Given this list of marker genes Stk32a, Nlgn2, Gpr26, Marveld3, Spo11, Vamp5, Fads3, Trpm6, Mettl24, Kcnip1, Phf1, Phox2a, Loxl4, Tsnax, Acp7, Tnfrsf25, Emilin3, Cdo1, Cimap1b, Gpx7, Abcc8, Rhcg, Dkk3, Lypd6b, Ccn2, Lhx3, Adora2a, Tbr1, Alox12, Hs3st2, Abtb3, Omp, Ddit4l, Taf7l, Grin2c, Znrf4, Glt28d2, Cdkl1, B3gnt8, Tacstd2, Tpm2, Rasd1, Gipc2, Grin3b, Anxa11, Large2 (NCBI Gene Id 99127), Cmtm7, Nrxn2, Pctp, Pcsk9, Nlrx1, Phactr3, Mex3a, Abcb1a, Eppk1, Syt16, Them7, Adss1, Hhat, Matn4, Efnb3, Slc39a8, Hebp1, Slc16a11, Npepl1, Npas4, Prrt3, Tubb4a, Pde4dip, Rnf17, Lekr1, Scin (scinderin), Chst5, Clvs2, Ptgis, Cspg4, Moxd1, Ctsz, Gfra3 (NCBI Gene Id 98132), Nox4, Aqp3, Terb1, Prdm14, Actl7b, Plscr4, Zfp641, Tmco4, Rpp25, Wnt3, Igfbp6, Parp14, Niban1, Cpne7, Scnn1b, 4930524B15Rik, Itgb4, Kcnh7, Selenov, Klhl14, Itpripl2, Dpp6, Fgf16, Gm5878, Naa11, Rarb, Cblc, Shroom1, Ppl, Prkar1b, Ssh3, Sowahd, Ripor2, Dusp9, Lin7b, Artn, Htra3, Mansc1, Krt19, Camkv, Dnajb3, Gsn, Tdh, Slc6a2, Rasgrf2, Gpr156, Prr15, Ezhip, 1700003F12Rik, Vsx2, Adamtsl5, Bmp8b, Bcat1 (branched chain aminotransferase 1, cytosolic), Irs3, Gpr176, Crispld2, Gldn, Sycp2 (NCBI Gene Id 83600), Dazl, Tfap2e, Ccn3, Gypc, Gpx3, Ifitm10, Galnt6, Mmp14, Slc44a3, Col26a1, Trim58, St14, Tmem30b (transmembrane protein 30B), Stat5a, Asic2, Mpv17l, 2810021J22Rik, Pcdhga11, Fgf22, Npy5r (neuropeptide Y receptor Y5), Cldn7, Pdgfd, Slc22a4, Gjb6, Trim25, Cd83 (CD83 antigen), Rassf10, Lpcat2, Oxtr, Sycp3, Il12rb2, Kcp, Cldn11, Gucy2e, Barhl1, Itga4, Grhl2, Clic6, Abcb9, Thbd, Cerkl, Ngb (NCBI Gene Id 64242), Rax, Cldn3 (claudin 3, NCBI Gene Id 12739), P2rx5, Adcy7, Pkp1, Cavin3, Ap1g2, Plekhg6, Mocos, Myocd, Slco2a1, Ccdc106, Sstr1, Ppp1r3b, Stac, Acot6, Sp5, Ap1s3, Cracr2b, Minar1, Rab42, Oxt, Mfsd6l (major facilitator superfamily domain containing 6-like), Fads6, C130074G19Rik, Ankrd53, Ngf, Larp6, S1pr3, Fah, Cxcl16, Fam83g, Ttc22 (tetratricopeptide repeat domain 22), Ntsr2, Ano5, Dhtkd1, Slc26a8, Ndrg2, Gna14, Gfra2, Tmem37, Shd, 1700001O22Rik, Bfsp1, Ky, Cpne9, Dhh, Rin3, Gabrq, Dusp26, Cyp2r1, Slc18a2, Lamc3, Wt1, Fut4, Slit1, Slc47a2, Mael, Gcnt1, Fbrsl1, Caln1, Mab21l1, Far2, Echdc2, Grin2a, Abcg4, Gal, Sptbn4, Pllp, Pkdrej, Fgfr4, Birc3, Nap1l5, D1Pas1, Gng13, Hormad1, Ccdc158, Gsdmd, Sowaha, Il27ra, Rasl10a, Cd302 (NCBI Gene Id 98862), Ece2, Rarg, Tmem171, Insrr, Lrrc15, Kremen2, Htr1f, Grb10, Mcub, Amn, Afap1l1, Eps8l2 (EPS8-like 2), Ush1g, Mapk13, Pitpnm1 (phosphatidylinositol transfer protein, membrane-associated 1), Cdcp1, Olig3, Fbln7, Trim36, Taf9b, Arhgap27, Cwh43, Rasef, Plbd1, Plcd1, Prrg3, Des, Pdlim2, Krt87, Glp1r, L3mbtl4 (L3MBTL4 histone methyl-lysine binding protein), Gmip, Slc47a1, Esyt3, Prom2, Cdx1, Castor1, Rem1, Slc9a3, Mpig6b (NCBI Gene Id 106722), B3gnt3, Trim47, Eef1a2, Sgk3, Nags, Gpr83, Dmc1, Vsir, Tdrd1, Arhgef4, Olfm2, Slc16a3, Myod1, Cygb, Bhlha15, Esrp2, Dcdc2a, Nr4a3 (nuclear receptor subfamily 4, group A, member 3), Liat1, Shisal2b, Papolb, Aldh1b1, Cdk18, Tcf20, Lpl (NCBI Gene Id 16956), P2rx2, Cst6, Kcnk4, St6galnac2, Tubg2, Evc, Ttc38, Nodal, Basp1, Kcna6, Ctsh, Thsd7b, Lhx9, Naprt, Spmip6, Myo5c, Car4, Drd5, Scarf2, Msh4, Shtn1, Col8a2, Dbx2, Ltb4r2, Kdf1, Lamc2, Fam163a, Fabp3, Lgals3, Tmprss2, Bhlha9, Qrfprl, Wdr86 (NCBI Gene Id 68216), Krt18, Pramel1, Prss50, Tspan2, Slc45a1, Dsc2, Klk8, Fstl3, Galr1, Sstr4, Nipal4, Or2i1, Speg, Crppa (NCBI Gene Id 75847), Ccdc125, Rnf225, Cldn4, Tfcp2l1, Loxl1, Flywch2, Lgi3, Vstm4, Agbl2, Hsf4, Krt7, Rnh1, Ntf3, Fam110c (family with sequence similarity 110, member C), Cd164l2, Lbx2, Il17rb, Cldn5, Pheta2, Ppm1j, Slc5a5, Htra4, Slc7a10 (NCBI Gene Id 53896), Foxi2, Kcnj6, Ric3, Eva1b, Spag6l, Fgf17, Cyp4v3, Tnfaip2, Scx, Ddx4, Sybu, Dnaaf6, Prkag2, Henmt1, Irf6, Kcnk13, Sox7, 5730409E04Rik, Gnmt, Syce2, Spag16, Bspry, Adad1, Ripply3, Ncmap, Tmem59l, Kcng1 (NCBI Gene Id 99379), Chmp4c, Doc2b, Kl, Rbm43, Prorsd1, Tdrd6, Aard, Slc30a2, Sec31b, Adgrg2, Tacr3, Tmem54, Ano1, Scara3, Sh3d21, Prlhr, Wnt10b, Sdr39u1, Paqr5, Hif3a, Irak3, Htatip2, Camkk2, Ntsr1, Ildr1, Cul9 (cullin 9), Ncoa4, Hand1, Ass1, Ltbr, Smc1b, Slc25a31, Cyba, F11r, F2rl1, Atp2a3, Adgrv1, Nscme3l, Isyna1, Flot2, Ap1m2, Hsf5, Slc13a3, Slc1a1, Cavin1, Rmdn2, Tnfrsf10b, Npb, Cyp24a1, Themis2, Kbtbd12, Hspa12a, Mmp23, Fkbp6, Ptger2, Cyp4f39, Gpr12, Sec1, Zfp709, Mgarp, Rbmxl2, Dsg2, Entpd2, Rab3b, Gca, Tnxb, BC030500, Arsj, Pgm5, Mycs, Fbxo17, Slc2a12 (NCBI Gene Id 353169), Cacng2, Irx4, Emid1, Lhfpl5, Parvb, Dlgap1, Slc6a11 (solute carrier family 6 (neurotransmitter transporter, GABA), member 11), Spata32, Adgre5, Thbs4, Slc34a2, Mmp25, Sycp1, Rgcc, Htr2c, Bcl3, Dpep3 (NCBI Gene Id 71854), Mal2 (NCBI Gene Id 223579), Map10, Pkib, Nipal2, Tmc8, Fgf20, Gsap, Casp8, Mcoln2, Sema4f, Dmgdh, Dmrta1, Pcnx2, Psd2, Arsi, P4htm, Pdha2, Shroom3, Mtarc1, Slc25a21, Osmr, Ehbp1l1, Lingo3, Spag6, Rhbg, Corin, Marveld2, Mesp2, Heyl, Spmap2l, Pik3r5, Afap1l2, Mmp2, Chrna3, Eogt, Drgx, Chchd10, Edn3, Kcnk9, Shfl, here is a description of the gene set: Genes with high-CpG-density promoters (HCP) that have no histone H3 methylation marks in neural precursor cells (NPC). DNA methylation is essential for normal development and has been implicated in many pathologies including cancer. Our knowledge about the genome-wide distribution of DNA methylation, how it changes during cellular differentiation and how it relates to histone methylation and other chromatin modifications in mammals remains limited. Here we report the generation and analysis of genome-scale DNA methylation profiles at nucleotide resolution in mammalian cells. Using high-throughput reduced representation bisulphite sequencing and single-molecule-based sequencing, we generated DNA methylation maps covering most CpG islands, and a representative sampling of conserved non-coding elements, transposons and other genomic features, for mouse embryonic stem cells, embryonic-stem-cell-derived and primary neural cells, and eight other primary tissues. Several key findings emerge from the data. First, DNA methylation patterns are better correlated with histone methylation patterns than with the underlying genome sequence context. Second, methylation of CpGs are dynamic epigenetic marks that undergo extensive changes during cellular differentiation, particularly in regulatory regions outside of core promoters. Third, analysis of embryonic-stem-cell-derived and primary cells reveals that 'weak' CpG islands associated with a specific set of developmentally regulated genes undergo aberrant hypermethylation during extended proliferation in vitro, in a pattern reminiscent of that reported in some primary tumours. More generally, the results establish reduced representation bisulphite sequencing as a powerful technology for epigenetic profiling of cell populations relevant to developmental biology, cancer and regenerative medicine. species: Mus musculus Mouse Gene Set: MEISSNER_NPC_HCP_WITH_H3_UNMETHYLATED from publication Meissner A, Mikkelsen TS, Gu H, Wernig M, Hanna J, Sivachenko A, Zhang X, Bernstein BE, Nusbaum C, Jaffe DB, Gnirke A, Jaenisch R, Lander ES (PMID 18600261)